Given this list of marker genes Smdt1, Micu3, Stoml2, Phb1, Micu1, Afg3l2, Pmpcb, Phb2, Yme1l1, Mcub, here is a description of the gene set: species: Mus musculus electronically inferred by orthology from the curated human pathway part of: Mitochondrial calcium ion transport This event has been computationally inferred from an event that has been demonstrated in another species.<p>The inference is based on the homology mapping from PANTHER. Briefly, reactions for which all involved PhysicalEntities (in input, output and catalyst) have a mapped orthologue/paralogue (for complexes at least 75% of components must have a mapping) are inferred to the other species. Reactome Pathway: Processing of SMDT1